The following is a description of a gene set: Human Gene Set: GSE37301_LYMPHOID_PRIMED_MPP_VS_RAG2_KO_NK_CELL_UP Expression profiling of Rag2-deficient Ets1++ and Rag2-deficient Ets1-- mature NK cells and WT bone marrow progenitors, WT T cells, and WT Pro B cells Genes up-regulated in lymphoid primed multipotent progenitors versus RAG2 knockout NK cells. species: Homo sapiens from publication Ramirez K, Chandler KJ, Spaulding C, Zandi S, Sigvardsson M, Graves BJ, Kee BL (PMID 22608498), and this is the list of marker genes: DYRK3, ZFR, EMC1, CDK12, BPNT1 (3'(2'), 5'-bisphosphate nucleotidase 1), AHCTF1, DPH2, BLTP3B, PMPCA, HEG1, TNFSF14, RPF1, ZC3H15, NRIP1, CCNJ, ABT1, NUDT15, NT5E, ATP6V0C (ATPase H+ transporting V0 subunit c), ZNF593, DIABLO, IRF8, PLEK2, LINC00115, JOSD1, RIF1, XPO4, RAN, IPO5, CYP27B1, SRPRB, PDHA1, SHB, TAF1A (NCBI Gene Id 9015), CSPP1, MCHR1, SYNJ2, MTRR, SAMSN1, PRMT5, RRP1, NDC1, AKAP1, ENO1, EIF3D, MYLK, SLC12A8, ETS2, KATNBL1, PPRC1, FUS (NCBI Gene Id 406232), EXOSC4, IPO4, CLUH, UTP18, DDX49, PPIF, PELI2, SATB1, TTC4, MON1B, PPP2CA, SLC22A4, HOXB3, MTMR11, HSPA9, OSBPL3, YARS1, PGAM1, LDHA, MYO1B, IL22, TOP1, TOMM20, GPR87, CSF1, GRSF1, EXOSC2, OXLD1, HGS, KDM6B, DDX24, PNO1, IRF6, KIF3B, RPP25, RNMT, TMEM30B, CUL4A, DUSP1, PLAGL2, MYOG, SEL1L, RGS2 (regulator of G protein signaling 2), MTERF3, PPAT, MCAT, OTUD4, MAPRE2, BTRC, CDKN1C (NCBI Gene Id 702), THRAP3, RRP12, POLR3C, TMEM147, CLTCL1, DDX56, TASOR2, EIF5B, UAP1, TIMM8A, EMP1, CHSY1, WARS2, NYNRIN, SRP19 (signal recognition particle 19), IL4, ATP1A1, TNS3, PAICS, TRAF3, ABCE1, ADAM9, SERPINB9, SERBP1, SCG2, AKAP8, EVI2A, CLEC11A, RIOX2, UTP6, BCL2L11, TMEM39A, CLPB, IDH3A, PRRX2 (NCBI Gene Id 51450), IRF4, EHD4, PTCD3, RRP1B, ZPR1, VEGFA, GAR1, WBP4, NFATC1, RCL1, RBPJ, SLC5A6, TENT5A, SDC4, PMAIP1, AMIGO2, NCL, EZR, OGFOD1, DDX21, TESK1, ITGA2, CLIC4, CD7, GABPB1 (NCBI Gene Id 82963), NUDT11, GCKR, NR3C1, UQCRC2, TSPYL2, POLR1B, MRPS2 (mitochondrial ribosomal protein S2), NELL1, ZNF614, RRS1, PSMA2, IL11, AHCYL1, SLC43A3, NUP54, EIF3G, CD48, FASTKD2, AIMP1, FXN, PRPF39, MEX3C, PALMD, ADSS2, RRP9, SERINC5, MRPL17, CPD, TRAF1, FCF1, CYP17A1, SFXN1, LDHB, SRSF6, SLC25A22, NCK2, CKB, RAB20